Given this list of marker genes GGT6, GGTLC2, GGTLC3, GGT3P, GGT2P, GGT5, GGT7, GGTLC1 (NCBI Gene Id 92086), GGT1, here is a description of the gene set: Catalysis of the reaction: glutathione + H2O = L-cysteinylglycine + L-glutamate. species: Homo sapiens Human Gene Set: GOMF_GLUTATHIONE_HYDROLASE_ACTIVITY